The following is a description of a gene set: studied in species Homo sapiens Human Gene Set: REACTOME_TRANSLESION_SYNTHESIS_BY_POLK Translesion synthesis by POLK, and this is the list of marker genes: REV3L, UBA52, POLK, RPA1 (replication protein A1), MAD2L2, UBC, RFC1, RPA2, RFC2, PCNA, REV1, RFC3, RPS27A, RPA3, RFC5, RFC4, UBB